The following is a description of a gene set: The process in which amyloid-beta is removed from extracellular brain regions by mechanisms involving cell surface receptors. Mouse Gene Set: GOBP_AMYLOID_BETA_CLEARANCE studied in species Mus musculus, and this is the list of marker genes: Tnf, Rab11a, Picalm (phosphatidylinositol binding clathrin assembly protein), Clu, Srf, Mme, Insr, Ifngr1, Cltc, Rab5a, Cyp51, Rock1, Lrpap1, C3, Hmgcr, App, Lrp4, Abcc1, Itgb2, Lrp1, Ldlr, Ifng, Itgam, Syk, Msr1, Myocd, Pla2g3, Trem2, Abca7, Il4, Rab11b, Igf1r, Marco, Ide, Ttpa, C5ar1, Apoe, Cd36, Lrp2